Given this list of marker genes ITGB2, MGLL, MIF, UBE2T, FEN1, MSH6, BIK, COPS2, FOXM1, EDEM3, CLEC11A, PANX2, LMO2, GCHFR, TNFRSF10B, EIF3B, CD99L2, HMGB2, MAFG, ACTG1, ATF5, EIF1AX, FLNA, PPP5C, CCNE2, CENPF, FOSL1, CSNK2A1, METTL9, ATP5PF, IRAK1, AKAP10, RAN, RFC4, APEX1, POLQ, ASPH, YWHAE, SMYD1, CD180, TPX2, TUBA1A, CTPS1, MAST2 (microtubule associated serine/threonine kinase 2), SEMA3B, ARPC2, MNDA, SIDT1, CCPG1, UNG, DAP, NMRK1, ITGB5, SMC2, TCF3 (transcription factor 3), PPAT, CSE1L, CDK5, BZW1, PHB2, PTPN7, ULBP2, MYB, ADK, ASPM, NEK6, SHMT2, NOLC1, MYC, PCDH1, PDXP, GMPS, ETV5, MGST2, ZNF347, MYO1E, PRMT1, IMPDH2, SLC25A22, NME4, CKS2, HSP90AA1, SLC43A3, ANKRD6, GTF2F2, RPA3 (NCBI Gene Id 6119), SLC25A5, ODC1, RCC1, HASPIN, MB, TNFRSF21, MAPKAPK3, ABCC1, AURKA, LINC00160 (long intergenic non-protein coding RNA 160), TFDP1, PECAM1, CDKN3, MAPK12, SLC20A1, GCC2, DYRK3, PLPP1, NOX4, TUBA1B, HDAC2, CAMK1, PRKCB, CKS1B, CYP2B6, MTFR2, DUT, HDGF, A2M, FBXO5, PCDHGC3, IFNGR2, FCGR1A, SLC25A33, BUB1, GFI1, UMPS, PIR, MECOM, NTAQ1, ITPA, RRM1, E2F1, MMP12, DENND3, YIF1B, FAM234B, CLPP, NME2, C1QBP, NCAPG2, DBF4, CDK4, CCND3, ELAVL3, IARS2, RFC3, PAICS, ZFAND3, ANGPT1, ANGPT2, RCN2, GPX1, PPEF1, MELTF, CCNB1, KHSRP, ADSL, CCNA1, DUSP3, PTPRN2, CD151, CDK1, ITGA3 (NCBI Gene Id 4454), CENPE, BLMH, PCNA (NCBI Gene Id 5111), MKI67, EDN1, CCNA2, CMYA5, HSPA5, TAF1D, TIMM44, COA7, GART, YWHAG, HDDC2, GLA, PPIF, ARL8B, SLC2A5 (solute carrier family 2 member 5), MELK, ILF2, CDC25A, ETV4, NOMO1, here is a description of the gene set: Lymphoma and immune response expression clusters. studied in species Homo sapiens Human Gene Set: MODULE_126